The following is a description of a gene set: A process in which muscle adapts, with consequent modifications to structural and/or functional phenotypes, in response to a stimulus. Stimuli include contractile activity, loading conditions, substrate supply, and environmental factors. These adaptive events occur in both muscle fibers and associated structures (motoneurons and capillaries), and they involve alterations in regulatory mechanisms, contractile properties and metabolic capacities. Human Gene Set: GOBP_MUSCLE_ADAPTATION studied in species Homo sapiens, and this is the list of marker genes: LMCD1, MSTN, NR4A3 (nuclear receptor subfamily 4 group A member 3), TOMM70, G6PD, IL1R1, GTF2IRD1, GATA5, KDM4A, MIR199B, CACNA1S, MIR499A, RGS4, SCN5A, MIR208A, TRPC3, CAV3, HAND2, MEF2A, FOXO3, MIR34C, LMNA, TWF1, NOS3, ROCK2, CFLAR, MIR199A1, EDN1, KLF4, ERRFI1, PARP2, IL1B, ARRB2, ATP2A2, MIR214, EZH2, PPARA, YY1, PPARG, MIR19B1, IGFBP5, PAK1, IGF1, PDE9A, SELENON, ACACB, ROCK1, HEY2, CAMTA2, MIR19A, PDGFRB, MIR21, TBCE, KLF15, CAMK2D, MIR34B, CAMK2B, PPP3CA, MLIP, PI16, NPPA, MYOG, MIR20A, MYOZ1, ADRA1A, HDAC4, MYOD1, PRKAG3, GSN, SMAD3, PDGFB, INPP5F, CERS1, P2RX4, SMAD4, MIR133A1, MYH6, ATP2B4, STUB1, GLRX3, SLC9A1, MIR25, ADCY10, APLNR, MTPN, RGS2, HMOX1, DAG1, CYBA, BECN1, TNFRSF1B, MYH7, TNNI1, MIR208B, ACTN3, TNFRSF1A, FBXO32, PRKCA, IL6ST, FOXP1, CTDP1, MIR145, MIR17HG, NOL3, AKAP6, TNNT1, GSK3A, NOTCH1, MIR17, CAMK2G, ASB2, MYOZ2, ARRB1, GATA6, AGT, BMP10, GATM, MIR1-1, FOXO1, TCAP, TRIM63, MYOC, PARP1, CASQ1, TNNC1, MYMK (NCBI Gene Id 389827)